The following is a description of a gene set: from publication Su Z, Ho JWK, Yau RCH, Lam YL, Shek TWH, Yeung MCF, Chen H, Oreffo ROC, Cheah KSE, Cheung KSC (PMID 38267611) Human Gene Set: SU_HO_FOETAL_FEMUR_C5_ENDOTHELIAL_CELL Endothelial cell cluster detected in the human foetal femur sample and contained conventional markers PLVAP, CLDN5, and CD93. The transformation of benign lesions to malignant tumours is a crucial aspect of understanding chondrosarcomas, which are malignant cartilage tumours that could develop from benign chondroid lesions. However, the process of malignant transformation for chondroid lesions remains poorly understood, and no reliable markers are available to aid clinical decision-making. To address this issue, we conducted a study analysing 11 primary cartilage tumours and controls using single-cell RNA sequencing. By creating a single-cell atlas, we were able to identify the role of endoplasmic reticulum (ER) stress in the malignant transformation of conventional central chondrosarcomas (CCCS). Our research revealed that lower levels of ER stress promote chondrosarcoma growth in a patient-derived xenograft mouse model, while intensive ER stress reduces primary chondrosarcoma cell viability. Furthermore, we discovered that the NF-?B pathway alleviates ER stress-induced apoptosis during chondrosarcoma progression. Our single-cell signatures and large public data support the use of key ER stress regulators, such as DNA Damage Inducible Transcript 3 (DDIT3; also known as CHOP), as malignant markers for overall patient survival. Ultimately, our study highlights the significant role that ER stress plays in the malignant transformation of cartilaginous tumours and provides a valuable resource for future diagnostic markers and therapeutic strategies. studied in species Homo sapiens, and this is the list of marker genes: UGCG, ADAMTS9, ECSCR, EMP1, TNFAIP8L1, C11orf96, RNASE1, PSMB9, DIPK2B (divergent protein kinase domain 2B), GTPBP2, AHR, HEG1, LRMDA, KIFC3, ABCG1, ENTPD1, PARP14 (NCBI Gene Id 54625), SHB, PRXL2A, PDE8A, PHC2 (NCBI Gene Id 1912), PGAP6, SMTN, CD34, MTSS1, TMEM44, EFNB2, HEY1, EXOC2, CALM1, DEPP1, PREX2, GGA1, EHMT1, RNF213, HIC1 (NCBI Gene Id 3090), PEAR1, SIGIRR, HIGD2A, MFNG, SKAP2, NHERF2, CLEC14A, ELK4, PGF, ESAM, EXOC5, STAB1, ARRDC2, PTPRG, CTNNA1, ROBO4 (roundabout guidance receptor 4), PTPRE, INPP5D, SVIL, GASK1B, VEGFC, VPS8, MTUS1, TCIM, GRB10, ATP8A1 (ATPase phospholipid transporting 8A1), PCAT19, CSNK1A1, BMP2K, TGFBR2, TACC1, SPRY1, SNRK, KDR, HOMER3, MAP1B, GABRE, MFSD6, DIPK1B, LRRFIP1, NEURL1B, LRRC32, HDAC7, IL3RA, ZNF467, MECOM, DYSF, NFKBIA, CARD8, SOCS2, PHF6, IGFBP3, RFLNB, RECQL, TNXB, FOLH1, C1orf54, MCF2L, RAC1, PTPRM, SIPA1L2, ZEB1, PXN, TGM2, CALCRL, ARHGEF28, GRK5, TSPAN18, CSNK1E, S100A16, ABHD17A, CRMP1, PRKCH, PEA15, SELENON, PODXL, ACVRL1, IER2, SOX17, BCL6B, SEMA3F, PLCB1, NFIB, USP31, CPNE5, ADAM15, FAM43A, CAVIN2, CLEC2B, EZH1, RANBP2, SLC39A10, FAM241A, DAZAP2, SOX18, JAM2, SHE, MIDEAS, TNFRSF25, AP1S2, PLK2, ITPKB, SPTAN1, RHOB, PCDH12, DPYSL2, STAU2 (staufen double-stranded RNA binding protein 2), PDE2A, ECE1, TNFAIP1, CAV1, CLEC3B, EPAS1, WWTR1, LMO2, ADGRF5, GNAI2, PRKD2, TCF15, EMCN, IRF2, FZD4, RBPMS, SVIP, LAMA5, NID1, MMRN2, RBM17, FHIP2A, NOVA2, S1PR1, NCOA3, KLHL5, CHST7, PLVAP, AFAP1L1, CXCR4, BAZ2B, PEAK1, PLEKHG1, CAVIN1, YWHAB, ADGRL2, CD93, BCAR1, SH3BP5, MAST4, MAFF, TAMALIN, PPP1R18, TNS1, MCTP1, ELF1, EGFL7, DOCK9, TP53I11, NCOA7, TJP1, RAPGEF3, FYN, LDB2, MAGI1, NOTCH4, SKIL, TMOD3, CYYR1, HSD17B11, LIMK2, RESF1, CCNY, MYO15B, PPM1F, FNBP1L, NEDD9, MCAM, PTPRB, NRIP1, CDH13, FXYD5, UTRN, ZBTB38, PDE10A, MYCT1, NPR1, ARHGAP26, HECW2, CDH5, JCAD, CD200, GNA11, PCDH17, RASAL2, GIMAP1, SMAD1, VPS13A, RAI14, DAPK3, SOCS3, SMAD6, CHD3 (NCBI Gene Id 1107), ARHGDIB, LEPROTL1, PALM, F2R, JAM3, PDE4D, IPO11, RNF19A, HDGFL3, SIPA1, IVNS1ABP, KCNN3, PROS1, ITPRID2, KAT6A, QPCT, FAM91A1, KALRN, CLDN5, FABP4, DUSP6, TTYH3, PPARG, HHEX, GARRE1 (granule associated Rac and RHOG effector 1), MAP3K3, GMFG, HYOU1, FKBP1A, BRI3, IL32, SHANK3, DOK4, SLC25A37, INSR, SLC12A2, SOS1, TSPAN9, CORO1C, EFNA1, SOX7, FLT4, AFDN, DOCK4, PKN1, ID1, ARL15, RAPGEF5, AGRN, ARPC5L, GRAMD1A, SLC2A3, DGKE, TMEM255B, RASSF2, DGKZ (diacylglycerol kinase zeta), KANK3, CDC42BPB, HIVEP2, KLF6, CPLX1, ADAM17, SHC2, LYST, AKAP12, JAG2 (jagged canonical Notch ligand 2), CREM, DYNLL1, ADGRL4, ADAMTS7, ASGR1, CFLAR, MMRN1 (NCBI Gene Id 22915), PML, TMEM184B, ELK3, ARHGEF3, PPP1R14B, TBX1, TIE1, TM4SF18, SH2D3C, RTN4, SNX25, DCHS1, ADAM9, DLL4, YES1, JUP, CMIP, KLF13, BCAM, HLX, SMG6, TUBA1A, LUZP1, ITPRIP, RBP7, RAMP2, ADCY4, SARAF, VWF, HCFC1, SPTBN1, ICAM2, DENND11, PLEKHO2, NECTIN2, CNTNAP3B (NCBI Gene Id 728577), FLT1, EDNRB, NBL1, GIMAP7, ITGA2, SH2B3, LRCH1, STARD3NL, ADGRG1, FGD4, TNFRSF10B, APLNR, MAN1A1, PIP5K1C, ARRDC3, KIAA1671, CREB5, ZSWIM6, TAX1BP3, LIMS1, PECAM1, PIP4K2A, BID, MPDZ, DENND3, CTTNBP2NL, TSPAN14, MIR181A1HG, GIMAP4, JUNB, RASIP1 (NCBI Gene Id 54922), ISG15, DUSP7, RASGRP3, CMTM6, COL21A1, BLCAP, CNRIP1, PLAAT3, CD2AP, GNAQ, KCNE3, TEK, GDPD5, C21orf91, SOX11, PALMD, TMEM204, AQP1, LYSMD2, HYAL2, DOCK6, TCF4, MAP4K2, SDF2L1 (NCBI Gene Id 23753), TMC6, VAT1, MEF2A, BCL10, GRAP, NOTCH1